Given this list of marker genes SLC30A8, TMEM163, SLC30A7, SLC30A5, SLC30A3, SLC30A2, SLC30A1, SLC30A10, SLC30A6, AP3D1, SLC30A4, here is a description of the gene set: Human Gene Set: GOBP_ZINC_ION_IMPORT_INTO_ORGANELLE species: Homo sapiens The directed import of zinc(2+) from the cytosol, across an organelle membrane, into the organelle.